The following is a description of a gene set: Genes up-regulated in B lymphocytes: naïve versus memory. In order to better understand the factors that regulate B cell differentiation upon exposure to antigen, we compares global gene expression profiles from naive B cells with antigen-specific plasma, germinal center, and memory B cells after immunization with the T-dependent antigen, NP-CGG. The memory B cell-enriched transcripts were then compared with memory T cell-enriched and hematopoietic stem cell-enriched transcripts in order to generate a transcriptional profile of self-renewal within the hematopoietic system. Human Gene Set: GSE4142_NAIVE_VS_MEMORY_BCELL_UP from publication Luckey CJ, Bhattacharya D, Goldrath AW, Weissman IL, Benoist C, Mathis D (PMID 16492737) species: Homo sapiens, and this is the list of marker genes: MYADML2, AVPR1A, HPD, FBXO30, SDC3, PLOD3, ACE, SLC22A2, KLHL28, RGS1, FGF19, DNAJB8 (NCBI Gene Id 165721), TMEM184B, DBNDD2, SIX3, BMPR2, WDR47, TBC1D8, TACR1, AADAC, DNAL1, CRYBB2, GPR88, RCAN3, NT5DC3, KCNAB1, P2RY13, TEX9, COL5A1, DCST2, HJURP, SPDYE18, NUMBL (NCBI Gene Id 9253), AMZ1, CD248, ACTR3B, KLF11, STX1A, GPR68, NNMT, HAND2, TRIM33 (NCBI Gene Id 80027), LELP1, OSBPL3, KRTCAP3, IL1F10, SLC39A2, ZNF474, RPL32, FAM163A, RNF185 (ring finger protein 185), CYP11B2, PPFIA1, CLRN3, CLDND1, LGI4, ZC3H12A, FAM170B, GAST, ITGA2B, ZBTB18, TMEM40, RHOF, CFAP43, ENTPD5, RORA, SH3RF3, LRCH3, SMAD7, SLC32A1, OXT, ACVR1, CCDC81, TMPRSS11A, GMFB, TUT7, KIAA0513, AMZ2, FKBP10, NECAP2, CRAT, SNED1, VAMP1, FMNL3, PRND, AOAH (NCBI Gene Id 313), SIGLEC10 (sialic acid binding Ig like lectin 10), KCTD14, RFESD, FAM149A, TNNC1, GLB1L, CCDC6, NOBOX, RRH, TCF25, DCTN5, HECA, AQP7, METTL21A, CD40, AKAP13, SCN4B, CHIT1, CPNE1, SORCS3-AS1 (SORCS3 antisense RNA 1), GALNT6 (polypeptide N-acetylgalactosaminyltransferase 6), HHIPL1, RC3H2, MBD3L1, TBC1D22A (NCBI Gene Id 25771), C8orf58, NKX6-1, SLN, LGR6, RENBP, PHF8 (PHD finger protein 8), EPGN, CNTROB, SLC6A18, EYA1, FKBP9, BMP10, TMEM119, DPM3, NKX1-2, LHFPL4, FLT3LG, N4BP1 (NEDD4 binding protein 1), PTPRN2 (protein tyrosine phosphatase receptor type N2), NINJ1, DENND2B, KRT33B, ERC1, TGFA, SNRPN, ENSA, CORO6, DSP, TRAPPC6B, FANCI, STRA8, ZNF627, TFAP2A (NCBI Gene Id 95131), GPR84, IRX1, AFMID, KRT14, LGALS8, VWA3A, DKKL1, LINC01973, DYNLT2, PLCG1, KRTAP3-1, MEIG1, ATP6V1G2, LINGO2, SOX13, ZNF205, TIFAB, ACVR2A, UBA7, SHLD2, RPS16, CRB1, GCM2 (NCBI Gene Id 9247), SNX22, CACNA1H, IFTAP, C19orf12, KIF1B, TP53INP2, KCNN3, EIPR1, ATP1A2, CFAP263, F3, SSTR3, IL1RAPL2, CLCA2 (NCBI Gene Id 9635), SLC49A4, AP3M2, TTC39B, SMIM3, NCMAP, TSPAN2, GCHFR, C1QTNF7, KIF5C, TNS2, TK2, LYPD2, HOXD13, C1QL2, ADCY5, DNAAF1, SLC36A1 (NCBI Gene Id 91974), MCRIP1